The following is a description of a gene set: part of: Membrane Trafficking After passing through the Golgi complex, secretory cargo is packaged into post-Golgi transport intermediates (post-Golgi), which translocate plus-end directed along microtubules to the plasma membrane. There at least two classes of clathrin coated vesicles in cells, one predominantly Golgi-associated, involved in budding from the trans-Golgi network and the other at the plasma membrane. Here the clathrin-coated vesicles emerging from the Golgi apparatus are triggered by the heterotetrameric adaptor protein complex, AP-1 at the trans-Golgi network membrane. The cargo can be transmembrane, membrane associated or golgi luminal proteins. Each step in the vesicle sculpting pathway, gathers cargo and clathrin triskeletons, until a complete vesicular sphere is formed. With the scission of the membrane the vesicle is released and eventually losses its clathrin coat. species: Homo sapiens Reactome Pathway: trans-Golgi Network Vesicle Budding, and this is the list of marker genes: TBC1D8B, BLOC1S1, CLTC, AP4S1, CLINT1 (clathrin interactor 1), ARF1, GBF1, AP3B1, CLTA, FTL, BLOC1S3, AP1S3, CLTB, APP, STX4, DNASE2, BLOC1S4, VAMP8, HSPA8, CLVS1, AP4M1, SNX9, CTSZ, AP1M1, HGS, TGOLN2, AP3S1, DNM2, NAPA, SNAPIN, NECAP1, PIK3C2A, BLOC1S6, HIP1R, AP1G2, AP1S1, VAMP7, PICALM, PUM1, SH3GL2, M6PR, IGF2R, SH3D19, GNS, GAK, DNAJC6, OCRL, ARRB1, RAB5C (NCBI Gene Id 5878), CPD (NCBI Gene Id 1362), YIPF6, AP1G1, SNX5 (NCBI Gene Id 27131), CLVS2, TPD52, SNX2, ACBD3, DTNBP1, AP1M2, AP4B1, TFRC, AP4E1, GOLGB1, SORT1, FTH1, CHMP2A, VAMP2, TXNDC5, AP1S2, AP1B1, SNAP23, TPD52L1